Given this list of marker genes IFNG, SLC11A1, ARHGAP1, RAB11B, FTMT (ferritin mitochondrial), SLC25A37, SLC25A28, NECTIN1, PGRMC2, SLC41A2, SFXN1, FLVCR1, SLC40A1, TFR2, STEAP3, LMTK2, MELTF, MMGT1, TFRC, LCN2, SLC48A1, HEPH, CLTC, MCOLN1, SLC46A1, FTH1, HAMP, B2M, FTL, HPX, ABCC5, MIR210, SCARA5, STEAP2, ABCB7, REP15, ABCB6, SLC11A2, TF (NCBI Gene Id 7018), SLC39A8, MCOLN2, ISCU, DNM2, CYBRD1, LTF, SLC39A14, FLVCR2, HFE, FTH1P19, STEAP4, ASIC3, SLC22A17, TTYH1, FTHL17, FXN, here is a description of the gene set: The directed movement of iron (Fe) ions into, out of or within a cell, or between cells, by means of some agent such as a transporter or pore. Human Gene Set: GOBP_IRON_ION_TRANSPORT studied in species Homo sapiens